The following is a description of a gene set: species: Homo sapiens Coenzyme A (CoA) is a ubiquitous cofactor that functions as an acyl group carrier in diverse processes including fatty acid metabolism and the TCA cycle. It is synthesized from the vitamin pantothenate in a sequence of five reactions. These reactions all occur in the cytosol or the mitochondrial intermembrane space. A recently described transport protein appears to mediate the uptake of Coenzyme A into the mitochondrial matrix. Reactome Pathway: Coenzyme A biosynthesis part of: Vitamin B5 (pantothenate) metabolism, and this is the list of marker genes: COASY, DCAKD, PANK1, PANK3, PANK2, PPCDC, PPCS